Given this list of marker genes HACD3, PLEKHG7, RALB (RAS like proto-oncogene B), DNMT3A, PDE8B, CSKMT, CASTOR3P, SDC2, ACSS3, ZMAT2, ATP6V1D, TMTC3, GATA3, SYCP2, SLMAP, SPIRE2, NPNT, FAS, KLRF1, PWP1, ACVR2B, GLOD5, BCL10, AASDHPPT, PNRC2, HIF1A, FBXO36, PAQR5, POLR1D, TMEM50B, KDSR, TFF1, SULT1C2, EPHA3, DHX40, NPAS2, CAPZB, DPY19L3, SV2C, DEDD2, CLIP2, OXSR1, IFI6, PALS1, TRAPPC6B, PARP16, BAG4, ENO2, SMIM17, PAPOLA, PBRM1, NBN, TET2, QRICH1, here is a description of the gene set: Genes predicted to be targets of miRBase v22 microRNA hsa-miR-5704 in miRDB v6.0 with MirTarget v4 prediction scores > 80 (high confidence targets). species: Homo sapiens from publication Chen Y, Wang X (PMID 31504780) Human Gene Set: MIR5704